Given this list of marker genes Bcor, Cckar, Gabrb1, Ranbp9, Rnd3, Nhlh1, Dnajc15, Adgrg1 (adhesion G protein-coupled receptor G1), Stard3, Fzd1, Chga, Dusp4, Cdkn1c, Hey1, Nrp2, Mfap2, Acly, Angpt1, Synpr, Nedd9, Pdk2, Nxph4, Abcd4, Thbs3, Trak2, Nptx1, Chrna3, Stat3, Tcf4, Nhlh2, Frmd4a, Dipk2a, Tenm4 (teneurin transmembrane protein 4), Ddit4, Pipox, Rapgef1, Nt5dc2, Dusp14, Mfap4, here is a description of the gene set: species: Mus musculus Genes expressed at higher levels in caudal regions beginning in the subventricular zone, in some cases extending into the intermediate zone and cortical plate of embryonic day 14.5 mouse cortex. Mouse Gene Set: HEVNER_CORTEX_CAUDAL_SUBVENTRICULAR_ZONE from publication Bedogni F, Hevner RF (PMID 34321999)